Given this list of marker genes WASF3, WASF1, WASF2, BRK1, CYFIP1, NCKAP1, ABI2, FCHSD2, here is a description of the gene set: species: Homo sapiens Any process that activates or increases the frequency, rate or extent of Arp2/3 complex-mediated actin nucleation. Human Gene Set: GOBP_POSITIVE_REGULATION_OF_ARP2_3_COMPLEX_MEDIATED_ACTIN_NUCLEATION